Given this list of marker genes RAC1, BDNF, TIAM1, NTRK2, CDK5R1, CDK5, here is a description of the gene set: studied in species Homo sapiens Human Gene Set: REACTOME_ACTIVATED_NTRK2_SIGNALS_THROUGH_CDK5 Activated NTRK2 signals through CDK5